The following is a description of a gene set: studied in species Homo sapiens Human Gene Set: MIR7107_3P Genes predicted to be targets of miRBase v22 microRNA hsa-miR-7107-3p in miRDB v6.0 with MirTarget v4 prediction scores > 80 (high confidence targets). from publication Chen Y, Wang X (PMID 31504780), and this is the list of marker genes: SRP9, PPP4R3B (NCBI Gene Id 57223), PPP1R9B, SRC, TENT2, SLC19A4P, SOX11, NFAT5, CERK, EVC, KSR2, SLC22A23, SERPING1, BICD2 (BICD cargo adaptor 2, NCBI Gene Id 23299), TBX5, CTHRC1 (collagen triple helix repeat containing 1), NFIA, DNAJC6, CREB3L3, SUPT7L, AUTS2, XPO5, CHD2, MTF2, RAD21, RAB11FIP4, PAPSS1, ASIC2, UBE2Z, NAA15, NAGPA, CLIP3, ADAMTS19, MBNL2, PRLR, NPHP1, SELENOT, PRG4, MON2, PIP5KL1, P2RY1, RC3H1, SPTBN1, SLC1A1, NDRG1, CTNND1, PDPK1, RAB30, TMEM91, SGSM2, THSD7A, GNAL